The following is a description of a gene set: species: Mus musculus This event has been computationally inferred from an event that has been demonstrated in another species.<p>The inference is based on the homology mapping from PANTHER. Briefly, reactions for which all involved PhysicalEntities (in input, output and catalyst) have a mapped orthologue/paralogue (for complexes at least 75% of components must have a mapping) are inferred to the other species. Reactome Pathway: GPER1 signaling electronically inferred by orthology from the curated human pathway part of: G alpha (s) signalling events, and this is the list of marker genes: Prkar2b, Prkaca, Gnb3, Gngt1, Prkacb (NCBI Gene Id 18749), Shc1, Gng8, Gng10, Gnb2, Prkar1b, Gng11, Gng3, Gngt2, Itga5, Gng4, Gng7, Gper1, Gnb5, Gng5